The following is a description of a gene set: Genes whose expression peaked at 60 min after stimulation of MCF10A cells with EGF. from publication Amit I, Citri A, Shay T, Lu Y, Katz M, Zhang F, Tarcic G, Siwak D, Lahad J, Jacob-Hirsch J, Amariglio N, Vaisman N, Segal E, Rechavi G, Alon U, Mills GB, Domany E, Yarden Y (PMID 17322878) Human Gene Set: AMIT_EGF_RESPONSE_60_MCF10A Signaling pathways invoke interplays between forward signaling and feedback to drive robust cellular response. In this study, we address the dynamics of growth factor signaling through profiling of protein phosphorylation and gene expression, demonstrating the presence of a kinetically defined cluster of delayed early genes that function to attenuate the early events of growth factor signaling. Using epidermal growth factor receptor signaling as the major model system and concentrating on regulation of transcription and mRNA stability, we demonstrate that a number of genes within the delayed early gene cluster function as feedback regulators of immediate early genes. Consistent with their role in negative regulation of cell signaling, genes within this cluster are downregulated in diverse tumor types, in correlation with clinical outcome. More generally, our study proposes a mechanistic description of the cellular response to growth factors by defining architectural motifs that underlie the function of signaling networks. studied in species Homo sapiens, and this is the list of marker genes: IL6 (interleukin 6), IER3, MGMT, MAGED2, PTGER4, ID1, PLK2, CCN2, MAP3K14, SLC35D2, JUNB, DAPP1, TPM1, ITGB6, TRIB1, GADD45A, CXCL8, TOMM22, IER2, ZC3H12A, JUN, C11orf68, KLF7, INHBA, RANBP3, DLC1, BHLHE40, HES1, PTGS2, CALD1, GLIPR1, EGR1, CXCL2, CCN1, SOWAHC, TP63, TNFAIP3, PDLIM5, RND3